Given this list of marker genes Supt20, Zfp637, Pwp1, Rom1, Rnh1, Bet1, Lyz1, Ppard, Nrf1, Fam91a1, here is a description of the gene set: Mouse Gene Set: CUI_NK_CELL_TRAIL_RESPONSE_UP species: Mus musculus from publication Cui A, Huang T, Li S, Ma A, Pérez JL, Sander C, Keskin DB, Wu CJ, Fraenkel E, Hacohen N (PMID 38057668) Genes positively differentially expressed in cell type: NK cell upon treatment with cytokine: TRAIL in mouse lymph nodes in vivo. Cytokines mediate cell-cell communication in the immune system and represent important therapeutic targets. A myriad of studies have highlighted their central role in immune function, yet we lack a global view of the cellular responses of each immune cell type to each cytokine. To address this gap, the authors created the Immune Dictionary, a compendium of single-cell transcriptomic profiles of more than 17 immune cell types in response to each of 86 cytokines (>1,400 cytokine-cell type combinations) in mouse lymph nodes in vivo. A cytokine-centric view of the dictionary revealed that most cytokines induce highly cell-type-specific responses. For example, the inflammatory cytokine interleukin-1β induces distinct gene programmes in almost every cell type. A cell-type-centric view of the dictionary identified more than 66 cytokine-driven cellular polarization states across immune cell types, including previously uncharacterized states such as an interleukin-18-induced polyfunctional natural killer cell state.